Given this list of marker genes PIWIL1, TDRD1, DNMT3L, SPOCD1, C19orf84, TDRD9, MOV10L1, PIWIL2, SPIN1, TDRD5, TDRD12, MAEL, PIWIL4, DDX4, DNMT3A, FKBP6, here is a description of the gene set: The formation of heterochromatin into a heterochromatin domain, enriched in histone H3 methylated on lysine 9 (H3K9me), by a process mediated by a Piwi-associated RNA (piRNA). species: Homo sapiens Human Gene Set: GOBP_PIRNA_MEDIATED_HETEROCHROMATIN_FORMATION